The following is a description of a gene set: An altered level of any enzyme to act as catalysts within erythrocytes. This term includes changes due to altered activity of an enzyme. studied in species Homo sapiens Abnormal erythrocyte enzyme concentration or activity Human Gene Set: HP_ABNORMAL_ERYTHROCYTE_ENZYME_CONCENTRATION_OR_ACTIVITY, and this is the list of marker genes: RPS15A, HK1, HEATR3, ITPA, GALK1, RPL9, ADA, RPS17, HMBS, BPGM (bisphosphoglycerate mutase), PHKA2 (phosphorylase kinase regulatory subunit alpha 2), RPL26, RPS7, RPL18, RPL5, GALT, KHK, RPS27, RPL15, RPS10 (NCBI Gene Id 6204), RPL35A, AK1, RPL35, ALAD, UROS, PRPS1, GALE, PKLR, RPL27, RPL11, CYB5R3, ALDOA, GCLC, GATA1, RPL8, RPS24, PIGA, RPS26, VPS13A, TSR2 (TSR2 ribosome maturation factor), RPL31 (NCBI Gene Id 6160), RPS19, GSR, RPS29, ADA2, RPS20, RPS28, ARG1, PHKG2